The following is a description of a gene set: species: Mus musculus Any process that stops, prevents or reduces the frequency, rate or extent of blood circulation. Mouse Gene Set: GOBP_NEGATIVE_REGULATION_OF_BLOOD_CIRCULATION, and this is the list of marker genes: Adcy10, Sptbn4, Grk2, Trpv1, Uts2, Bin1, Pde5a, App, Tnf, Sri, Atp2a2, Fkbp1b, Adra1a, Atp1a2, Rnls, Tac1, Adra1d, Spx, Pde4d, Gjd3, Pik3r1, Atp1a1, Pln (phospholamban), Zc3h12a, Ager, Chrm3, Agtr2, Npff